The following is a description of a gene set: The ternary complex factor Net/Elk3 is downregulated in hypoxia and participates in the induction by hypoxia of several genes, including c-fos, vascular endothelial growth factor and egr-1. However, the global role of Net in hypoxia remains to be elucidated. We have identified, in a large-scale analysis of RNA expression using microarrays, more than genes that are regulated by Net in hypoxia. In order to gain insights into the role of Net in hypoxia, we have analysed in parallel the genes regulated by HIF-1alpha, the classical factor involved in the response to hypoxia. We identified about genes that are regulated by HIF-1alpha in hypoxia. Surprisingly, when we compare the genes induced by hypoxia that require either Net or HIF-1alpha, the majority are the same (75%), suggesting that the functions of both factors are closely linked. Interestingly, in hypoxia, Net regulates the expression of several genes known to control HIF-1alpha stability, including PHD2, PHD3 and Siah2, suggesting that Net regulates the stability of HIF-1alpha. We found that inhibition of Net by RNAi leads to decreased HIF-1alpha expression at the protein level in hypoxia. These results indicate that Net participates in the transcriptional response to hypoxia by regulation of HIF-1alpha protein stability. species: Mus musculus from publication Gross C, Dubois-Pot H, Wasylyk B (PMID 17704799) Human Gene Set: GROSS_HYPOXIA_VIA_ELK3_AND_HIF1A_UP Genes up-regulated in SEND cells (skin endothelium) at hypoxia after knockdown of ELK3 and HIF1A by RNAi., and this is the list of marker genes: SMOX, SDC4, EDN1, GZF1, VEGFA (NCBI Gene Id 7422), NDRG1, HELT (helt bHLH transcription factor), ARHGAP5, SPRY4, PGK1, CRTC3, KLF6, ZBTB20, ERRFI1, CYRIB, CCN1, ARX, MAPK6, MAGED1, ANGPTL4 (angiopoietin like 4), DDX39B, CLCN5, MERTK, TPI1, PTCH1, PSMC4, ANKRD1, SAT1, CD44, RARS1, JMJD6, CCN2, SOX2, DUSP14, JAG1, APPL2, PFKFB3, FAM162A, HK2, CDC42EP3, SPAST, PLK2, PTGER4, PLPP3, WSB1, FRMD6, RND1, DEPP1, LHX9, MXD1, CYP21A2, GATA3, ZFP36, NAP1L1, IL13RA1, PRDX5, PDK1, ZNF330, RNGTT, CNOT7, KCTD11, CD93, VWA1, PNRC1, RGS16, SERTAD2, ME2, MXI1, RPS6KC1, ALDH1L2, MPP2, HIGD1A, RPS6KA5, CSRNP1, RUSC2, SRGN, PALLD, P4HA1, HBEGF, AIMP2, NEDD4L, ETS1, BNIP3, ATP7A (NCBI Gene Id 613259), ATF3, MAP3K1, PDPR, SLC19A1, KLF4, JMJD1C, NFKBIA, TCIM, FOS, NAGPA, RBPJ, ANXA2, ENO2, HOMER1, PIM3, KIF5A, PPP1R3B, DUSP4, SELENBP1, SLC2A1, SIAH2, PGAM1, VHL, GBE1, PGF, ARL6IP5, CAVIN3, XPNPEP1, ACAP2, RORA, NEDD9, RCAN1, SGK1, EGR1, HILPDA, BCL10, TRAF6, AFG3L2, GPRC5A, AK4, CHIC2, DUSP16, INSIG2, LXN, RCOR1, NFKBIZ, CDC42SE1, SLC37A4, DNAJB4, SOAT1, TM4SF1, PHLDA1, NOCT, PPRC1, SPRY2, TNC, TGIF1, LRP5